The following is a description of a gene set: Human Gene Set: BUSSLINGER_DUODENAL_EARLY_IMMATURE_ENTEROCYTES studied in species Homo sapiens from publication Busslinger GA, Weusten BLA, Bogte A, Begthel H, Brosens LAA, Clevers H (PMID 33691112), and this is the list of marker genes: VDAC1, DDC, TXN, SUCLG1, CALM2, DHRS11, RPL6, GSTA2, COX7B, PNP (NCBI Gene Id 4860), RPL8, PTGR1, PYCARD, RPS29, FABP2, PSME2, FTL, SLC2A2, KRT8, HMGCS2, RBP2, AADAC, NDRG1, DMBT1, ANXA4, IDH1, CYC1, CA2, ATP5MC3, RPL26, CAT (catalase), PEBP1, ANPEP, UGT2B17, LGALS3, COX5B, SLC25A5, AKR1A1, COX8A, HADHA, COX4I1, ADA, COX5A, CYB5A, RPS8, MME, ATP5F1B, FABP1, ATP1B1, ALDH1A1, PIGR, COX7A2, CRYL1, GSTA1, CPS1, ATP5PF, PRDX1, CMBL, ATP5PO, EEF1G, PBLD (NCBI Gene Id 64081), LIMA1, RAC1, BDH2, MGST3, RPS15A, ATP5F1A, GHITM, UQCRQ, OAT, KLF5, SMIM24, CES2, ATP5F1C, SLC4A4, SI, GATM, SLC4A7, RPS7, ATP1A1, COX6A1, CBR1, MTTP, RPL22, SLC5A1, SAT1 (spermidine/spermine N1-acetyltransferase 1), SNHG29, KRT20, ADH1C, PCK2, LGALS4, TKFC, TSPAN8, RPL23, HEBP1, MAOA, SLC26A3, COX6C, RPL27A, FTH1, CHP2, RPS9, HSD17B2, REEP6, GBA3, COX7C, KRT19, FBP1, AKR1B10, CHCHD10, AKR1C3, UQCRC2, CALM1